The following is a description of a gene set: The developmental process, independent of morphogenetic (shape) change, that is required for a columna/cuboidal epithelial cell of the intestine to attain its fully functional state. A columnar/cuboidal epithelial cell of the intestine mature as they migrate from the intestinal crypt to the villus. species: Mus musculus Mouse Gene Set: GOBP_INTESTINAL_EPITHELIAL_CELL_MATURATION, and this is the list of marker genes: Hoxa5, Tyms, Tmigd1, Hif1a, Fzd5, Cdkn1a